The following is a description of a gene set: studied in species Mus musculus Integrin-mediated cell adhesion Mouse Gene Set: WP_INTEGRINMEDIATED_CELL_ADHESION, and this is the list of marker genes: Shc3, Hras, Itgad, Capn7, Itga11, Raf1, Mapk7, Sorbs1, Cav2, Itga10, Itgb8, Map2k5 (NCBI Gene Id 23938), Cav1, Arhgef7, Rap1a, Dock1, Actn1, Itgb7, Ptk2, Mapk10 (mitogen-activated protein kinase 10), Vav3 (vav 3 oncogene), Src, Pak2, Rac3, Ilk, Shc1, Rac2, Tns1 (NCBI Gene Id 98418), Pxn, Git2, Itga9, Mapk1, Rock1, Itgb2, Grb2 (NCBI Gene Id 14784), Mapk12, Braf, Pak3, Akt3, Zyx, Capn3, Vav2, Itgb4, Itga1, Vcl, Itga7, Itgb1, Csk, Itgae, Akt1, Araf, Capn5, Capn2, Capn10, Pak1, Rap1b, Selenop, Itgav, Sos1, Akt2, Rac1, Itgb6, Itgb5, Itga8, Cav3, Capn9, Map2k3, Rho, Pak6, Itga6, Pdpk1, Crk, Cdc42, Tln1, Itga5, Itgam, Capns1, Map2k2, Mapk4, Mylk2, Map2k1, Itga3, Capn11, Capn6, Itgb3, Rock2, Itgax, Map2k6, Rapgef1, Pik3r2, Itga2b, Capn1, Itga2, Vasp, Mapk6, Pak4, Fyn, Itga4, Itgal, Bcar1